The following is a description of a gene set: species: Homo sapiens Genes up-regulated in comparison of untreated CD4 T cells versus those treated with TGFB1 and IL6. from publication Lee Y, Awasthi A, Yosef N, Quintana FJ, Xiao S, Peters A, Wu C, Kleinewietfeld M, Kunder S, Hafler DA, Sobel RA, Regev A, Kuchroo VK (PMID 22961052) TGF-beta3 produced by developing Th17 cells induces highly pathogenic T cells that are functionally and molecularly distinct from TGF-beta1-induced Th17 cells. The microarray data represent a distinct molecular signature for pathogenic versus non-pathogenic Th17 cells. Human Gene Set: GSE39820_CTRL_VS_TGFBETA1_IL6_CD4_TCELL_UP, and this is the list of marker genes: SAMSN1, OTX1, HMCES, TENT5A, SAMD9L, MTDH, UBIAD1, VRK2 (NCBI Gene Id 7444), POM121 (NCBI Gene Id 9883), LGALS7, ATAD1, HMGCR, SNX9, DUSP5, PPP3CA, GPR174, EVL, RUVBL1, PITHD1, AEN, TARDBP, TG, RFWD3, MORF4L1, MRPS28, PISD, RPP14, SHTN1 (shootin 1), TOP1, NMRK1, SLBP, SETDB1, DNMT3B, SHQ1, SEC11C, SELL, POLR1F, ANKRD13C, PTS, BAX, AIM2, TNFSF11, DNAJC15, DBR1, PDIA5, CSN2, ENO3, CBX1, GRAMD1B, DDIAS, CBX4, CTH, C3orf80, NRN1, SLCO4A1, MBNL3, OBI1, MRPL39, C5orf22, ATP8B4, SMARCA5, PLXNC1, DCUN1D3, RPA2, DNMT3A, TOX, PTPRE, PHLDA1, PSMB8, RNF152, CA12 (carbonic anhydrase 12), ASAP1, UNG, PIGC, ALG8, SERPINC1, CSF2, PUS3, ANKRD44, PTDSS1, PENK, ARHGEF6, TEX15, NEFH, FH (fumarate hydratase), SLC12A8 (solute carrier family 12 member 8), CD96, COMTD1, CD1D, TMEM131L, NOP10, EGR3, ZNF592, KCNQ5, TET1, PTRH2, ZNF281, SARNP, DFFB, ST8SIA4, TIPIN, WDR75, CTSS, SEPHS1, MAP3K8, ST8SIA6, PDCD1LG2, KIF20B, GLRX, CD81, CRIM1, RCSD1, ZCCHC2, ITK, BID, NCOA2, CWC22, TMPO, GPR183, FAM98B, RAB19, AMPD2, GSTO1, FILIP1L, HMGCS1, PKP4 (NCBI Gene Id 8502), FAM111A, PHF6 (PHD finger protein 6), RAD50, DTWD1, GAS2, WDHD1, CNOT6L, CDC40, PTER, RHOD, HMGN3, HSPD1, DHX33, LAPTM4B, CASP3, MTRR, ASF1A, SLC4A7, PTGER4, CORO2A, DDC, BUB3, ARAP2, DTYMK, DNMT1, SUCLG2, SKP2, PLXND1, CREB1, INPP1, HSPE1 (heat shock protein family E (Hsp10) member 1), CENPM, STK26, SETD6, DGLUCY, RREB1, SLC23A2, KANSL2, SPIN4, PARP12, ZNF280B, LIN7A, IL6, NRROS, PAG1, SLC35A1, QRSL1 (NCBI Gene Id 80136), APOBEC1, MRPS31, TFRC, INSIG1, GPR34, BAG4, DPP4, UROS, ERGIC1, ITGB1 (integrin subunit beta 1), USP25, C12orf75, PPIP5K2, LYPD6B (LY6/PLAUR domain containing 6B), CCT3, IFIT2, RAP2B, FRRS1 (ferric chelate reductase 1), DOCK11, RFC5, PLXNA1, DENND2D, RAMP3, PTPN11, FYN, SMARCAD1